Given this list of marker genes BEND4, HSD17B8, ANTXR1, EVA1A, CLCC1, XCL1, PCP4L1, RELN, MAP1A, B3GNT2, SLAMF8, ZBTB34, PRKD1, TOMM6, PARVB, CNNM3, SLC16A2, NOS1, LARP4, CAPS, JADE2, FGF20, SKAP1, IMMP2L, CDS2, AFF4, KLF4, ABI2 (abl interactor 2), LRRIQ3 (NCBI Gene Id 654248), CHRNA9, CSRP1, CCSER1, ITSN2, ERICH1, GORASP1, PNP, COPS4, ITGA11, GPC4, ATXN7L3B, INTS10, CD44, DSTYK, ARPC2, MTOR, SMARCA1, TNFAIP2, FBXO32, ANKIB1, CNGB3, POU2F3, NSFL1C, CPSF2, SERTAD3, ACSL5, ATRN, MAFB (MAF bZIP transcription factor B), PPM1L, ATP8A1 (ATPase phospholipid transporting 8A1), GSTO2, ESYT3, MITF, RPS3A, DEDD, HACD2, NR3C1, ZNF597, ATOSB, POU2F1, TTC9 (tetratricopeptide repeat domain 9), TACC2, CDCA2, here is a description of the gene set: species: Homo sapiens Genes predicted to be targets of miRBase v22 microRNA hsa-miR-4471 in miRDB v6.0 with MirTarget v4 prediction scores > 80 (high confidence targets). Human Gene Set: MIR4471 from publication Chen Y, Wang X (PMID 31504780)